Given this list of marker genes MIR21, MSTN, TNFRSF1B, G6PD, SMAD4, CERS1 (ceramide synthase 1), TNFRSF1A, FOXP1 (NCBI Gene Id 87246), MIR25, YY1, MIR1-1, NOTCH1, IGFBP5, MIR133A1, BMP10, TOMM70, PPARA, RGS2 (regulator of G protein signaling 2), CTDP1, MLIP, PI16, MIR214, LMNA, STUB1, GSK3A, PPARG, SMAD3, MIR145, TRIM63, GLRX3, RGS4, CAV3 (NCBI Gene Id 859), PAK1, MIR199B, P2RX4, ERRFI1, GATA5, MIR199A1, APLNR, FOXO1, ATP2B4, here is a description of the gene set: studied in species Homo sapiens Any process that stops, prevents, or reduces the frequency, rate, or extent of muscle hypertrophy. Human Gene Set: GOBP_NEGATIVE_REGULATION_OF_MUSCLE_HYPERTROPHY